The following is a description of a gene set: species: Homo sapiens Human Gene Set: REACTOME_FBXL7_DOWN_REGULATES_AURKA_DURING_MITOTIC_ENTRY_AND_IN_EARLY_MITOSIS FBXL7 down-regulates AURKA during mitotic entry and in early mitosis, and this is the list of marker genes: PSMD13, PSMB3, SEM1, PSMD2, RBX1, PSMB5, PSMC1, PSMA1, PSMC2, PSMB4, PSMD6, UBA52, PSMB2 (NCBI Gene Id 5690), PSMC3, PSMA2, CUL1, PSMD1, PSMD11, PSMB6, UBC, UBB, FBXL7, PSMA6 (proteasome 20S subunit alpha 6), ADRM1, AURKA, PSMA4, PSMC6, PSMD12, PSMB7, RPS27A, PSMA3, PSMD8, FBXL18, PSMD14, PSMA5, PSMD7 (proteasome 26S subunit, non-ATPase 7), PSMC5, SKP1, PSMD3, PSMA7, PSMC4, PSMB1